Given this list of marker genes EXTL2, EPGN, CXADR, CLEC7A, RFX4, ZNF652, RC3H1, MDM1, SPIN2A, CDKL5, CTNNA1, DCDC2 (doublecortin domain containing 2), NFYA, KPNA4, GLS, LAP3, LIN28B, CADM2, USP49, H3-3B, DOCK10 (NCBI Gene Id 9714), LSM8, PLEKHB2 (pleckstrin homology domain containing B2), LMAN1, AKAP13, ZMYND8, MMS22L, PSD3, RHOB, NIN, KRT28, AKAP5, HS6ST2, HNRNPA1L2, MAP1B, ABCE1, MKLN1, SLC22A3, MBD2, C12orf43, SDC2, TRAF3, PCDH17, MBNL3, DOC2A, GOLGA6L9, EEA1, EYA1, TET1, LRATD2, OTP, NUP54, XIAP, FZD3, ZFX, DISC1, NABP1, RFX3, FHIP2A, SLC24A3, CREBBP, FAT1, VAMP4, MELK, UBE3C (NCBI Gene Id 9690), CCDC28A, RALGAPB, RPEL1, SLITRK4, ZNF831, YWHAB, ADAM28, AZIN1, LRP2, IMMT, ADGRL4, PPP1R15B, OIP5, PHACTR2, RADX, TAL1, SLC5A1, PDGFRA, METTL2A, RAB21, FOXN3, SVIL, CFH, ZNF24, NFAT5, PHF20L1 (NCBI Gene Id 84165), GRM7, MSI2, WAPL, ADAM17, SNAP47, RPS27L, KHDRBS2, SPAST, AGFG1, C1GALT1C1, APP, SYT14, SLC39A10, ZNF519, NEXMIF, VN1R1, CREBZF, CBX5, PRELID2, PBX1, TNFRSF19, PNMA2, RC3H2 (ring finger and CCCH-type domains 2), CAMSAP2, GOLGA8T, GPATCH2L, GOLGA8A, SSPN, REST, CHN2, BPNT2, FAM76A, TRIB2, PGM2L1, CNNM4, SRSF11, PYGO1, GABPA, C16orf95, GPR180, TNRC6B, NPY2R, CHRNA6, KMT2C, LIFR, CALCOCO1 (calcium binding and coiled-coil domain 1), SRGAP2B, SYN2, C1orf115, MAP2, CNOT6L, PRDM1, PEDS1, MAGI2, RFX7, LACC1, HACE1, ZBTB34, NR4A1, GOLGA6L10, PPM1B, MAB21L1, PPP4R3A, KIF1B, UTY, EME1, SMARCAD1, POLK, HDX, CFAP47, VSX1, NEDD4, ZFTA, DCTN4, RAD21 (NCBI Gene Id 5885), STAG1, TLE3, FOXQ1, SEMA3C, TMEM178A, POGZ, RBL2, NCKAP5, NR2E1 (NCBI Gene Id 7101), FMR1, PAX5, POLR1D, PRDX6, METAP1, BTRC, PPP1R17, SLC16A10, PAK5 (NCBI Gene Id 57144), GABRP, MIB1, GCSH, CCN1, ATL2, USP21, SLC44A1, NUDT4, TJP1, PPP1R12A, GTF2H2, LRPPRC, PDIA3, THAP2, CEP20, PFKM, LUZP2, UNC13A, ABCA5, RETREG1, LCOR, HTATSF1, SNX27, CDYL2, KIF16B, CDS2, MAL2, PACRGL, SLC30A6, SLC35A1, DPY19L1 (NCBI Gene Id 23333), GOLGA6A, NIT2, ANK2, DDX42, PRP4K, PRKACB, PTPRM, MCFD2, PRSS12, FAM91A1, CCSER1, FGFR2, PPARGC1A (NCBI Gene Id 10891), MNAT1, IDS, C19orf47 (NCBI Gene Id 126526), PPP1CC, ZBTB43, MTMR9, FLVCR2 (NCBI Gene Id 55640), SS18, ARID2, ZNF680, KCNC2, SMARCA5, GAD1, GOLGA8B, ZC3H12B, BRINP2, PMP2, SIM1, TENT4A, DENND6A, COMMD3-BMI1, KCNMB2, CCDC148, STRBP, ARL13B, HSPA13, LNX2, MOB1B (MOB kinase activator 1B), FNDC3A, CEP57L1, TMEM164, TTC28, KLHL28, KATNAL1, KLHL2, COX15, GOLGA6L4, USP31, SLC17A6, PSMD10, TMEM239, TNIK, P2RY1, GPR83, TSC22D1, UHMK1, GNG2, CCNI, TBC1D32, FBXL3, HNRNPD, ZZZ3, RASGRF2, IL24, ANGPTL1, ZNF451, PIP5K1B, USP37, FAM169A, EPHA5, HERC4, IL1RN, FAM83A, OGFRL1, RCOR1, PDE1C, MAPK1, SHANK2, HYCC2, GLUL, TBX5, HNRNPA1, STK26, VAPA, STRIP2, NFIB, ZBTB20, ZNF84, PER1, HACD1, ARMCX2, MLIP, CRIM1, MMGT1, SPIN1, ZFHX4, ZNF280D, TMEM144, TRERF1, NUP93, NCOA1, TSPAN7, PCLO, EDIL3, CTBP2, PHF14, CPEB2, FMN2, SCAPER, PPP3R1, SOX21 (SRY-box transcription factor 21), ELOVL6, EMB, PCDHA9, NAA50, ARID4B, ZNF512, LRP6, KLHL1 (kelch like family member 1), MRTFB, CPNE8, NTRK2, GOLGA8M, CPEB1, CREB1, NHLH2, GOLGA8R, CHD9, SYNCRIP, ADCY1, PALMD, RCAN2, GOLGA6C, MTARC1, DMD, FGF13, MED13, REEP1 (receptor accessory protein 1), MICU2, PPP2R2A, USP10, CALCR (NCBI Gene Id 799), PITPNA (NCBI Gene Id 5306), TOGARAM1, GOLGA8Q, INPP4A, CFHR1, TNFAIP3, TRIM2, GRM5, INO80D, TMEM59 (transmembrane protein 59), TMC5, CDKN1A, JUNB, CTBP1, FRY (FRY microtubule binding protein), ZBTB41, NTF3 (neurotrophin 3), FRMD6, GPM6A, LRRK2, UFSP2, CSRNP3, CYB5R4, CD36, CEBPG, FER, OLFM3, GPR34, SPOP, TRMT10B, GARRE1, ZMIZ1, CHMP4B, CCNG2, S1PR3, DENND1B, TTC39C, MDH1, TRIO, BCLAF1, TMED7-TICAM2, YPEL1, ABHD13, LONRF1, SMIM13, CHD2, PTPN3, MAGEH1, KDM6A, PCDH10, SPRY4, HP1BP3, SLC6A14, DCUN1D5, MTDH, ADGRF4, TMEM255A, CASC3, LRRC58, SLC28A1, SMAD2, KIAA1191, MESP1, RASSF8, PGBD5 (NCBI Gene Id 79605), FSD1L, CWC22, COP1, CXCL14, CAMK2D, ASB7, ATP6V0B, PAN3, UGDH, LZTS2, TCF7L2, CACHD1, LAPTM4A, PIGA, NR3C1, RLIM, SH3PXD2A, ACLY, RET, GOLGA6D, PPP4R4, CEMIP2, KLF15, ATG4C, ABHD16A, RAB12, ABI1, KIF26A, TBPL1, MORN4, HTR2C, UNC45B, LMO4, PTPN21, WEE1, NBN (nibrin), CCDC71L, TAF4B, TNKS2, LGALSL, SLITRK1, NR6A1, SPRY1, PIK3R3, SAMTOR, GABRB2, ARHGAP36, POGLUT3, FAM98B, TGFBR1, HTR5A, METTL15, SNAP91, OTUD4, STX2, WDFY1, RICTOR, RBM44, ALG6, HNRNPA3, RABEP1, PPAT, FZR1, TANC1, CISD2, PAK6, METTL2B, NIPSNAP2, MAPK9, TMEFF1 (transmembrane protein with EGF like and two follistatin like domains 1), DIXDC1, DLL1, SAMD8, TRIM33, ADGRG6, ZBTB44, ST8SIA4, RSF1, NDN, STMN1, CDK17, SLC16A1, GOLGA6B, PPP1R14C, SAMD4A, FUT9, AP4E1, MED26, NKX3-2, SPRYD7, CDK19, PJA2, EID2B, ARHGAP12, SYT17, DNER, DSCAM, CACNB4, FOXO1, ARHGAP32, SORCS3, here is a description of the gene set: Genes predicted to be targets of miRBase v22 microRNA hsa-miR-4719 in miRDB v6.0 with MirTarget v4 prediction scores > 80 (high confidence targets). Human Gene Set: MIR4719 species: Homo sapiens from publication Chen Y, Wang X (PMID 31504780)